Given this list of marker genes Hspa1a (heat shock protein 1A), Nsf, Hspa8, Clpb, Hspa1b, here is a description of the gene set: studied in species Mus musculus Mouse Gene Set: GOMF_ATP_DEPENDENT_PROTEIN_DISAGGREGASE_ACTIVITY An ATP-dependent molecular chaperone activity that mediates the solubilization of ordered protein aggregates.